Given this list of marker genes TTC3, SKIL (NCBI Gene Id 6498), NRP1, RRAGD, SLC40A1, LPAR4, ANKRD12, SMYD1, ATP9A, RGS1, PLAT, ARMC7, INSM2, ZSCAN29, FUT9, SBK1, SP110, SMAD7, SPAG17, SPSB1, STX16, RNF208, YPEL3, WBP1L, GPR158, LDLRAD3, ITGAE, ATXN1, DAPK2 (NCBI Gene Id 23604), LPXN, NIPSNAP3B, NDRG4, B4GALT3, DBNDD2, PPOX, PRG4, CCR8, CPD, FCHSD2, MTMR3, BLTP2, NRARP, PHLDB2, SMPD5, PTPRO, P2RY1, SNORD89, HTR1F, CHD3, FMNL3, B3GNT8, CTSW, CHDH, SESTD1, NDNF (neuron derived neurotrophic factor), TMEM186, KCTD14, RPL4, MYO9A, SLC18B1, PLIN4, SIPA1, CFAP418, CLXN, GTF3C1, NINJ1, ELK3, RASGRP3, PACS1, TSPYL2, FOXN1, FAM3C, FURIN, GIT2, ZNRF1, USP22, STAT3, COL1A2, EPB41L3, C19orf12, ABCA1, NCMAP, KCTD13, GREB1L, CIB3, CYP11B1, AQP3, RAB3D, COL7A1, LMBR1, IGSF11, CD40, ABL1, BORCS6, IGF2R, PPIL2, NLRP6, SPAG16, MAP7, FREY1, ZNF319 (NCBI Gene Id 57567), PDE2A, SLC39A14, ST8SIA1, DIAPH2, CDC14B, SMURF2, NDFIP2, ALDH18A1, PRKCG, STMN2, ATF7IP2, GTF2IRD1, RIC3, IPCEF1, CERK, EXOG, AKT3, MAPKBP1, ZBTB18, SPTAN1, ZNF398, MACO1, NIPAL1, MEX3A, PRKAG2, POU6F1, LDLRAP1, CTIF, GNG2, ACCS, MYRIP, KLHL25, FRMPD3, RGS16, MYO3B, PDGFRL, ENDOD1, GOLM1, GPR63, ZBTB20 (zinc finger and BTB domain containing 20), C14orf39, AOC3, CABYR, ATP1A2, IKZF4, HS1BP3, MINK1, SLC11A1, PLCE1, GUCY1B1, ROBO1, NR6A1 (NCBI Gene Id 2649), TTC19, FKBP1B, ACSL6, MAP1LC3A, SKI, CUX1, AMOT, SYNGR2, RNF149, TNFRSF13C, BHLHE40, GREB1, CRTC3, PPP1R1C, CARD6, N4BP1, TBC1D16, CCDC134, DPCD, CWH43, HCAR2, CASP7, MTUS1, BIN3, NT5E, ALOX15, CACNG5, FNDC11, CD38, FKBP10, AKAP5, IL18R1, TPH1, CD96 (NCBI Gene Id 337949), SRC, RPS6, TRAPPC3, ANKRD50, MTA3, MED22, ARHGEF4, CAMK2N1, SYCP2L, GPER1, OAF, LDLRAD4, here is a description of the gene set: The transcription factor Foxp3 is usually considered the master regulator for the CD4+CD25+ studied in species Homo sapiens from publication Hill JA, Feuerer M, Tash K, Haxhinasto S, Perez J, Melamed R, Mathis D, Benoist C (PMID 18024188) Human Gene Set: GSE7460_CTRL_VS_TGFB_TREATED_ACT_TREG_DN Genes down-regulated in comparsion of ActTreg versus ActTregTGF (see Fig. 1 in the paper for details).